The following is a description of a gene set: studied in species Homo sapiens Human Gene Set: GOMF_CYCLIC_NUCLEOTIDE_DEPENDENT_PROTEIN_KINASE_ACTIVITY cNMP-dependent catalysis of the reaction: ATP + a protein = ADP + a phosphoprotein., and this is the list of marker genes: PKIA, PRKAA1, PRKACG, PRKAG2, PRKG1, PRKX, PKIG, PRKAG1, PRKY, PRKACB (protein kinase cAMP-activated catalytic subunit beta), PRKG2, PPP1R1B, PRKAR1A, PRKAR2A, PRKAR1B, PRKACA, PRKAR2B, CXCL10, PKIB, SMO